The following is a description of a gene set: Cytokines mediate cell-cell communication in the immune system and represent important therapeutic targets. A myriad of studies have highlighted their central role in immune function, yet we lack a global view of the cellular responses of each immune cell type to each cytokine. To address this gap, the authors created the Immune Dictionary, a compendium of single-cell transcriptomic profiles of more than 17 immune cell types in response to each of 86 cytokines (>1,400 cytokine-cell type combinations) in mouse lymph nodes in vivo. A cytokine-centric view of the dictionary revealed that most cytokines induce highly cell-type-specific responses. For example, the inflammatory cytokine interleukin-1β induces distinct gene programmes in almost every cell type. A cell-type-centric view of the dictionary identified more than 66 cytokine-driven cellular polarization states across immune cell types, including previously uncharacterized states such as an interleukin-18-induced polyfunctional natural killer cell state. Mouse Gene Set: CUI_LANGERHANS_TNFA_RESPONSE_UP species: Mus musculus Genes positively differentially expressed in cell type: Langerhans upon treatment with cytokine: TNF-α in mouse lymph nodes in vivo. from publication Cui A, Huang T, Li S, Ma A, Pérez JL, Sander C, Keskin DB, Wu CJ, Fraenkel E, Hacohen N (PMID 38057668), and this is the list of marker genes: Tmem243, Lgmn, Jag1, Mat2a, Actg1, Adprh, Rassf2 (NCBI Gene Id 99374), Idi1, Irf1, Ntmt1, Rin3, Csrp1, Tbc1d14, Gtpbp4, Etv6, Ccl17, Pim1, Bcl2a1d, Ahnak, Ifitm2, Ndrg1, Znfx1, Ehd1, Vwa5a, Cxcl1, Pdlim5, Cd302, Snx10, Clic4, Sft2d2, Samsn1, Cd83, Actr3, Fscn1, Mapre2, Atp11a, Tcaf2, Gsap, Ube2e3, Myl12a, Dock10, Bcl2l1, Rnf19b, Tmpo, Marcks, Tbc1d1, Crebl2 (cAMP responsive element binding protein-like 2), Epc1, Flnb, C1qa, Anxa2, Srgn, Rapgef2, Ralb, Rasgef1b, Serpinb9, Gpr183, Nans, Necap2, Wnk1, Itm2c, Nrros, Fchsd2, Serpinb6b, Nudt17, Txn1, Cdk5r1, Rab8b, H2-T23, Prr14, Ly75, Fam107b, Tmbim6, Ccr7, Sike1, Cst3, Rbms1, N4bp1, Nfkbia, Mpv17, Nrp2, Gtf2b, Filip1l (filamin A interacting protein 1-like), Tbc1d8, Spata31d1b, Bcl2a1a, Arpc2, Plppr4, Psme2 (proteasome (prosome, macropain) activator subunit 2 (PA28 beta)), Bcl2a1b, Atp2b1, Tmem39a, Marcksl1, Litaf, Plaat3, Pvr, Tagln2, Il10ra, Prnp, Serinc3, Chd8, Arhgef40, Adra1a, Ebi3, Csf1, Calcrl, Calm1, Abracl, Ccnd1, Asap2, Nfkbib, Cd70, Spint2, Nudt9, Trim35, Tmem131l, Avpi1 (NCBI Gene Id 69534), Ccl22, Basp1, Rasa2, Pik3r5, Mkrn1, Glipr2, Myh9, Dscaml1, Cd86, Cd40, Pik3r1, Tnnt2, Plscr1, Lcp1, Cd82, Itgb8, Igsf8